Given this list of marker genes ZNF207, SRP19, PSMA1, ACTR3, SNRPD3, RBM3 (RNA binding motif protein 3), CDV3, PANK2, PPP6C, FAM120A, PSMB1, SMNDC1, EIF3D, GDI2, SUMO2, HNRNPK, MAPK1IP1L, SF3A1, YY1, IK, PAPOLA, TMA7, SAP18, PSMD4, ATP5MG, RTRAF, WAPL, MAPRE1, SRSF3, CCDC59, KCMF1, UBA52, PSMG2, UBE2D3, ARF6, POP4, DAP3, RNF138 (ring finger protein 138), SNW1, here is a description of the gene set: Neighborhood of PPP6C protein phosphatase 6, catalytic subunit in the GNF2 expression compendium species: Homo sapiens Neighborhood of PPP6C Human Gene Set: GNF2_PPP6C